Given this list of marker genes Bcl2l11, Prc1, Dnah2, Rmdn3, Dcdc2c, Fbf1 (Fas binding factor 1), Krt80, Cnp, Cct2, Shroom2, Twf2, Incenp, Map3k1, Synm, Gm5414, Cct3, Reep3, Ryr3, Dcdc2b, Tfpt, Dcxr, Kcnn3, Bfsp1, Iffo1, Cab39, Ppl, Kif12, Col5a2, Rpl17, Sco2, Kif9, Kif1b, Radil, Krtap6-5, Cttn, Mdm1, Nckap5, Timp4, Adamts10, Shroom1, Clip2, Kif17, Krt5, Apoe, Abraxas2, Tpm1, Dnai1, Tekt5, Map7, Gas2l3 (NCBI Gene Id 71530), Calm3, Ctps2, Haus4, Kif1c, Ttll3, Arl6, Kif24, Fermt2, Fam110a, Map2k2, Rmdn1, Ggps1, Specc1, Psrc1, Cimip2c, Csrp3, Tnnt2, Trim63, Crhbp, Parva, Myh13, Krt73, Synpo2, Kif26a, Cacna1d, Kptn, Saa2, Cfap53, Nbr1, Dynll2, Polr2m, Clasp1, Dnm1, S100a1, Stau2, Dbn1, Eln, Nefl, Klc1 (NCBI Gene Id 16593), Cfap210, Mfap2, Pacrg, Dnaja3, Adra1a, Abcc9 (ATP-binding cassette, sub-family C member 9), Myo18a, Kif3c, Dusp21, Spmip11, Coro1a (coronin, actin binding protein 1A), Tnnc1, Capn6, Haus1, Mefv, Arpc3, Tiam1, Lmna, Flnc (NCBI Gene Id 68794), Diaph3, Csnk1d, Dnah12, Krt26, Myh14, Tubb4b, Map6, Cd2ap, Scn1a, Tube1, Cfap20, Fyn, Klhl40, Rsph1, Syne1, Fhdc1, Wipf1, Col27a1, Daxx (NCBI Gene Id 13163), Krt2, Krt78, Mtm1, Spmip10, Arpc2, Krt13, Efhc1, Krt4, Anxa1, Nckap1, Cfap144, Kcnj8, Map2 (NCBI Gene Id 17756), Pbxip1, Tubb3, Palld, Clip3, Appbp2, Krt12, Hspb1, Nicn1, Col4a6, Sorbs2 (NCBI Gene Id 77324), Dsp, Fbn2, Chmp7, Cald1, Krtap19-2, Gas7, Cep170, Ttll4, Gas8, Kifc5b, Pgm5, Cct6a, Dnai2, Krtap7-1, Whamm, Kcne1, Birc5, Myl12a, Krt77, Mfap1a, Tubgcp6, Cavin4, Xirp2, Tubb6, Col5a1, Dcn, Col11a1, Rusc1, Ckap5, Ankrd1, Myh4, Mt3, Ppp1r12b, Zfp804a, Ankrd2, Krt72, Kif18b, Alppl2, Tchp, Numa1, Myzap, Tpm2, Mapre3, Krt74, Sarm1, Cst3, Snca, Tpt1, Mybpc3, Krt83, Slc8a3, Tubgcp3, Odam, Tmsb15b2, Col2a1, Chmp1a, Map2k1, Chmp6, Arhgef2, Nudc, Arhgap18, Krtap19-4, Nrap, Synpo, Tubgcp5, Psma6, Ninl, Hook2, Capzb, Efcab6, Krtap5-1, Cdk5r1, Krt87, Rtn2, Klhl41, Frg1, Col4a3, Reep4, Myom2, Nrp1, Katna1, Unc45b, Bmp10, Pawr, Hsph1, Actr3, Krtap3-2 (NCBI Gene Id 66708), Kif1a, Myo5a, Krt84, Klhl22, Rassf3 (Ras association (RalGDS/AF-6) domain family member 3), Myh11, Cenpj, Tppp2, Akap13, Actg2, Dnm1l, Parvb, Aldoa, Lmntd2, Dnal1, Kif3a, Map1s, Prph, Spmip5, Diaph1, Lmod3, Rac1, Rassf5, Fign, Krtap15-1, Mtmr12, Map1a, Map10, Clasp2, Spef1, Lcp1, Col4a4, Ccdc57, Ctsh, Tuba1a, Vim, Aurka, Col28a1, Chmp2a, Dst, Krt6b, Iqgap1, Pierce2, Cdk5rap3, Rab3d, Jam3, Pafah1b1, Tubb2b, Fmn2, Rac2, Kcnn1, Spag5, Myoz2, Mypn, Fsd1, Smtnl1, Cfap90, Vps18, Dync1li2, Lima1 (NCBI Gene Id 73742), Zw10, Saa1 (NCBI Gene Id 20208), Hook3, Tpx2, Haus7, Krt36, Actn4, Neb, Krtap5-4, Kifc1, Krt7, Hck (NCBI Gene Id 99093), Cdk5rap2, Map1lc3a, Myo1a, Tekt2, Tuba8, Cfap276, Tpm3, Reep1, Tubg2, Kntc1, Rpl4, Grk3, Ndrg1, Dvl1, Txndc2, Krt20, Tubgcp2, Vmac, Ppp3ca, Krtap5-3, Cobl, Dlg1, Nos1ap, Fhl2, Coro1b, Dynll1, Myo18b, Dcdc2a, Lman1, Tuba1c, Tubal3, Lum, Krt85, Ank3, Map3k11, Snph, Tnni3, Dnajb6, Grin2b (NCBI Gene Id 14812), Kif16b, Nusap1, Col4a2, Cfap161, Evpl, Gck, Misp, Myo1c (NCBI Gene Id 97728), Eml4, Capn3, Myh1, Rac3, Ank1, Bbln, Kif21a, Lmod1, Kif23, Cldn11, Sh2b2, Cfap206, Map1lc3b, Vps11, Krt71, Odf2, Ckap2, Efhb, Sqstm1, Gm5478, Ror2, Fhl5, Rmdn2, Mtus2, Krt75, Gabarapl1, Sdc4 (syndecan 4), Wdr44, Tuba4a, Krtap19-3, Csrp2, Fkbp4, Spmip6, Cdk5, Kif11, Nav1, Mid2, Tcp1, Tuft1 (tuftelin 1), Sirt2, Tjp1, Bin1, Simc1, Myod1, Mfap4, Prkd1, Krt8, Fam110c, Col4a1, Fbxo32, Gas2l1, Trim32, Haus8, Abra, Dag1, Cct7, Fhl3 (four and a half LIM domains 3), Synj2, Chmp4b, Fhod3, Dpysl2, Tnnt3, Nos1, Tcap, Togaram2, Smpx, Acte1, Camsap3, Dcx, Casp1, Myl12b (NCBI Gene Id 98057), Tubb2a, Map6d1, Dnm3, Dnal4, Cep57l1, Dnah3, Tbca, Bcas3, Myo9b, Map9, Actc1, Kif13b, Fam161b, Dctn2, Myl3, Iqgap2, Slc2a1, Pdlim5 (NCBI Gene Id 99766), Kif5b, Myoz3, Cfap45, Tpgs1, Hook1, Whrn, Lrpprc, Nek2, Rpl6, Disc1, Fgf13, Macf1, Tubb5, Ryr2, Cacna1c, Fbn1, Ccdc181, Flna, Chmp2b, Calm2, Dynlt3, Myl4, Psen2, Slc1a4, Kifc3, Krt39, Krt16, Pycard, Cfap141, Actn3, Trip10 (NCBI Gene Id 106628), Cmya5, Narf, Ddx6, Dnajb4, Myo1b, Rhoq, Saxo1, Hdac4, Krt35, Gja1, Hdac6, Slmap, Tpm3-rs7, Yes1, Stmn1, Diaph2, Hrc, Myoz1, Invs, Vcl, Lrrc39, Scn3b, Dync2h1, Enkur, Nme7, Krtap21-1, Acta1, Krt17, Kif2a, Dynlt2a1, Krt33a, Col1a2, Tuba3a, Klc4, Krt6a, Gsn, Mmp2, Kif18a, Atp2a1, Cdk2ap2, Ak1, Tnk2, Aurkb, Flacc1, Spaca9, Krt23, Ttn, Dbi, Fbp2, Arhgap4, Gsk3a, Ccdc66, Spmip8, Kif7, Chmp1b, Ttll9, Twf1, Dpysl3, Ina, Tektip1, Actb, Krt28, Adprhl1, Hid1, Tbcb, Chmp1b2, Rab11a, Dmd, Actg1, Ltbp1, Bag3, Spast (NCBI Gene Id 54171), Krtap16-1, Myh7, Kif15, Myo3a, Ryr1 (ryanodine receptor 1, skeletal muscle), Jakmip1, Pierce1 (piercer of microtubule wall 1), Casp14, Myh8, Parp4, Kif19b, Gfap, Specc1l, Upp2, Fam161a (family with sequence similarity 161, member A), Aurkc, Bfsp2, Selenos, Flnb, Gper1, Saxo4, Cul3, Arf1, Ska1, Katnb1, Gdpd2, Pdlim4, Gramd2b, Odf1, Eml6 (echinoderm microtubule associated protein like 6), Trpv4, Emd, Mid1ip1, Dync1li1 (NCBI Gene Id 93741), Camsap2, Spag6l, Htr2a, Fkrp (NCBI Gene Id 243853), Ank2, Kcnn2, Polb, Fbln5, Tlk2, Dynlrb1, Septin9, Kat2b, Klc3, Tsc1, Cfap107, Sco1, Marcks, Krt90, Ezr, Serp1, Col11a2, Kif22, Jup, Cryab, Dynlrb2, Krtap4-6, Saxo2, Rcc2, Cep162, Lrrc10, Afap1, Tekt4, Kif27, Cacna1s, Haus2, Tmem232, Rpgrip1l, Slc8a1, Myom3, Krt76, Stk11, Kcnab2, Map1b, Myh10, Cdk1, Togaram1, Ido1, Arl3, Dyrk1a (NCBI Gene Id 76465), Mfap5, Src, Krt19, Spag8, Ptges3, Eif3a, Scn8a, Krt15, Ttll6, Arfgef2, Inpp5d, Gas2l2, Krtap19-5, Slc8a2, Myl7, Opa1, Acta2, Kif20a, Nckap5l, Mx2, Jph2, Krtap9-3, Igbp1, Bcl10, Fkbp1b, Krt82, Clip4, Haus3, Tpm4, Cspp1 (NCBI Gene Id 72327), Odf4, Cltc, Krt222, Bex4, Dync1h1, Ky, Cfap95, Bysl, Efhc2, Tubb1, Zfp207, Dmtn, Sptbn1, Cfap77 (NCBI Gene Id 669829), Aspm, Srprb, Spag17, Nes, Rgs14, Kctd6, Ppp2r5a, Synpo2l, Styxl2, Aif1l, Avil, Stub1, Ttll13, Adamtsl5, Haus5, Plec, Smn1, Mapt (microtubule-associated protein tau), Sphkap, Cimip2b, Fbxl22, Fmn1, Camsap1, Luzp1, Nde1 (nudE neurodevelopment protein 1), Tmem214, Apc, Tekt1, Mid1, Hnrnpu (NCBI Gene Id 98724), Katnal1, Kif21b, Fbxo22, Cyp2a4, Myh6, Lmnb1, Golga2, Krtap26-1, Ift70a2, Npnt, Chmp5, Amot (angiomotin), Casq1, Krt42, Akap4, Cstpp1, Krtap6-2, Cep57, Plk1, Espn, Abi2, Dctn3, Tmsb15l, Cimap1a, Pls1, Krtap19-1, Nme1, Ctnnb1, Mybpc1, Krtap5-5, Nin, Eml5, Krt81 (NCBI Gene Id 64818), Mtcl2, Slc4a1, Ino80, Mns1, Kif3b, Kif2c, Arhgef25, Myh2, Cimip2a, Dync2li1, Pyroxd1, Krt24, Dynlt1b, Ctps1, Ndel1, Pdlim1, Kif20b, Krt86, Pof1b, Dek, Dnah1 (NCBI Gene Id 630521, dynein, axonemal, heavy chain 1), Krtap3-1, Krtap19-9b, Pygm, Dctn1, Fam83h, Cyp2a5, Pde4dip, Csnk1a1, Adora2a, Clip1, Ift70b, Tmod1, Iffo2, Myl9, Igfn1, Ankrd23, Krt10, Ska2, Mapre2, Cep295, Ttll5, Eml2, Pcnt, Spry2, Scn5a, Klc2, Col5a3, Dync1i2, Mfap1b, Krtap16-3, Tmod3, Tnni1, Tubgcp4, Ocm, Tuba1b, Fbxw11, Cfl2, Ska3, Eif6, Cct8, Ppp1r12a, Ttll8, Fxr1 (NCBI Gene Id 99741), Cenpe, Baiap2, Nefh, Dlc1, Pak1, Des, Bex6, Aif1, Col4a5, Ilk, Kifc2, Pde4d, Homer1, Dbnl, Haus6, Nebl, Kif5a, Myl2, Tmod4, Myot, Casq2, Bod1, Glrx3, Atat1, Gng12, Ltbp4, Sptan1, Mta1, Dysf, Dync1i1, Cimap1d, Krtap14, Wdr47, Kif4, Katnal2, Tubd1, Lmntd1, Mybpc2, Myo9a, Spmip9, Obscn, Ptpn20, Mybph, Ackr2, Myh9, Rpl15, Mark2, Dusp22, Matcap1, Actn2, Cct5, Tekt3, Mical1, Dnm2, Kbtbd13, Gsk3b, Pgm1, Krt33b, Drd4, Map7d2, Cfap52, Kif28, Shroom4, Kif2b (NCBI Gene Id 73470), Mical2, Hcls1, Tnni2, Tmod2, Myom1, Stim1, Shank2, Cotl1, Dapk3, Krtap29-1, Syne2, Myh3, Trim54, Chmp4c, Cep170b, Apc2, Pecam1, Bag2, Tek, Krt79, Gjb6, Krt18, Krt40, Ssna1, Fkbp1a, Nexn, Wdr90, Rem1, Sync (NCBI Gene Id 68828), Cct4, Kif19a, Klhl21, Krt34, Dnah8, Tubg1, Was, Mef2c, Krt9, Col6a1, Map4, Tpgs2, Ribc1, Keap1, Sctr, Kif6, Shroom3, Dnai7, Krtap8-1, Myo1f, Grip1, Spag4, Pkp2 (NCBI Gene Id 71741), Krt14, Ccsap, Cfap68, Cav3, Pcp4, Ttll1, Cfap126, Myo6, Actbl2, Ribc2, Rpl7, Atp2b4, Tcp11l1, Knstrn, Krt1, Mybphl, Pdlim7, Enkd1, Lmnb2, Tppp3, Bicd1, Septin2, Ttll10, Sri, Csrp1, Sybu, Kcna5, Tnnc2, Myh7b, Krtap3-3, Kif26b, Gabarap, Mtcl1, Sntb2, Itgb1bp2, Fbln1, Fez1, Myh15, Chmp3, Rtl1, Pls3, Asb2, Dnah17, Col10a1, Jph1, Akna, Shtn1, Dnah5, Cfap96, Carmil1, Vps16, Col1a1, Pdlim2, Actn1, Tppp, Ttll7, Clmp, Tnnt1, Krt27, Anxa5, Tektl1, Keg1, Bloc1s6, Dctn4, Gtse1, Eml1, Kif13a, Habp4, Lrrc49, Kif5c, Thsd4, Nefm, Ttl, Synj1, Eppk1 (epiplakin 1), Krtap12-1, Kif14, Nav3, Ift70a1, Lzts2, Tubb4a, Ldlrap1, Efemp2, Eml3, Ldb3, Kifap3, Slain1, Ppp3cb, Nme2, Krt32, Krtap5-2, Cyld, Rassf1, Krt25, Trpc1, Prickle4 (NCBI Gene Id 381104), Lmod2, Dpp9, Reep2, Calm1, Mapre1, 3425401B19Rik, Myl1, Pdlim3, Slain2, Col3a1, Ttll11, Krt31, Hspa8, Rnf4, Svil, Ablim2, here is a description of the gene set: A polymeric supramolecular structure. species: Mus musculus Mouse Gene Set: GOCC_SUPRAMOLECULAR_POLYMER